The following is a description of a gene set: Human Gene Set: GOBP_POSITIVE_REGULATION_OF_NUCLEOTIDE_BINDING_DOMAIN_LEUCINE_RICH_REPEAT_CONTAINING_RECEPTOR_SIGNALING_PATHWAY studied in species Homo sapiens Any process that activates or increases the frequency, rate, or extent of a nucleotide-binding domain, leucine rich repeat containing receptor signaling pathway (NLR) pathway., and this is the list of marker genes: SLC15A4 (solute carrier family 15 member 4), SLC15A3, HSPA1A, HSPA1B, NAGK, SLC46A2 (solute carrier family 46 member 2), TLR4